The following is a description of a gene set: part of: Cytokine Signaling in Immune system studied in species Homo sapiens Reactome Pathway: Signaling by CSF3 (G-CSF) CSF3 (GCSF) is a cytokine that regulates production of neutrophils and granulocytes. CSF3 circulates extracellularly as a dimer and binds to the monomeric receptor CSF3R (GCSFR) on neutrophil precursors and mature neutrophils. CSF3R possesses no catalytic activity of its own and is constitutively associated with the kinases LYN and JAK1. Upon binding the CSF3 dimer, CSF3R dimerizes, is phosphorylated, and activates JAK-STAT signaling, RAS-RAF-MEK-ERK signaling, and PI3K signaling.<br>After dimerization of CSF3R, JAK1 associated with CSF3R is required for phosphorylation of tyrosine residues in the cytosolic domain of CSF3R which recruit further kinases such as JAK2, SYK, HCK, and TYK2. Phosphorylated JAK1 and JAK2 then appear to act redundantly to phosphorylate STAT proteins (STAT1, STAT3, STAT5) which dimerize and transit to the nucleus to activate gene expression.<br>CSF3 signaling also activates the RAS pathway, resulting in activation of ERK1 and ERK2 and cellular proliferation. Phosphorylated CSF3R recruits both GRB2, which can act as a scaffold for RAS guanyl exchange factors SOS and VAV, and PTPN11 (SHP2), which activates RAS by dephosphorylating tyrosine-32 of RAS. Association of SOS or VAV with the phosphorylated CSF3R has not yet been shown. The pathway to activation of PI3K is uncertain but appears to proceed via GAB2 bound to CSF3R.<br>Mutations in CSF3R can occur during the course of Kostmann disease, a severe congenital neutropenia. Somatic mutations in CSF3R, principally truncations of the C-terminal region, are involved in the pathogenesis of severe congenital neutropenia and are associated with progression to acute myeloid leukemia. Loss or mutation of the C-terminal region of CSF3R interferes with inhibition and turnover of the receptor. Mutation of Thr-618 to Ile-618 in CSF3R causes spontaneous dimerization and consequent autoactivation leading to CSF3-independent signaling and chronic neutrophilic leukemia., and this is the list of marker genes: GAB2, STAT5B, RNF7, JAK1, STAT1, STAT5A, UBE2D1, PTPN11, SHC1, TYK2, CSF3, GRB2, UBB, UBC (ubiquitin C), UBE2D2, STAT3, SYK, UBE2D3, UBA52, JAK2, ELOC, ELOB, LYN, SOCS3, SOCS1, CUL5, KRAS, RPS27A, HCK, CSF3R